The following is a description of a gene set: beta-Oxidation, peroxisome, VLCFA. Pathway ID: N00776. Pathway type: Reference. Pathway class: nt06021 beta-Oxidation in peroxisome. Pathway Definition from KEGG: Very-long-chain-acyl-CoA(n) -- ACOX1/3 >> HSD17B4 >> (ACAA1,SCP2) -> Very-long-chain-acyl-CoA(n-2) studied in species Homo sapiens Human Gene Set: KEGG_MEDICUS_REFERENCE_BETA_OXIDATION_PEROXISOME_VLCFA, and this is the list of marker genes: ACOX3, HSD17B4, SCP2, ACOX1, ACAA1